The following is a description of a gene set: Mouse Gene Set: MIR_329_3P studied in species Mus musculus Genes predicted to be targets of miRBase v22 microRNA mmu_miR_329_3p in miRDB v6.0 with MirTarget v4 prediction scores > 80 (high confidence targets). from publication Chen Y, Wang X (PMID 31504780), and this is the list of marker genes: Grb2, Atp2a3, Rp2, Plaur, Luc7l2, Atxn1, Pcdha11, 4930596D02Rik, Fam53c, Piwil1, Pcdhac1, Ahnak, Ebf2, Zdhhc21 (NCBI Gene Id 68268), Bpifc, Ptchd4, Dclk1, Mark1 (NCBI Gene Id 98697), Bcl7a, Myo1b, Snrk, Kcnj5, Rnf19b, Dusp10, Nemp1, Ccer1, Ubn1, Zfyve1, Gigyf1, Ddx47, Pcdha6, Chmp3, Akap8, Npy5r, Pcdha4 (NCBI Gene Id 98129), Usp25, Tceal8, Atp11c, Lnpk, Dync2i2, Hey1, Trak1, Shb (NCBI Gene Id 230126), Ptprj, Bmerb1, Tnrc6b, Adam9, Csnk1g3, Mcf2l, Srsf4, Rmnd5a, Pcdha5, Map3k8 (mitogen-activated protein kinase kinase kinase 8), Ptx3, Slc17a6, Rabgap1, 1700028K03Rik, Zfp239, Mllt6, Arhgap11a (NCBI Gene Id 228482), Slc8a1, Pfkfb2, Larp4b, Pcdhac2, Rai1, Mapre1, Clec2h, Foxo1, Ppp1r14c, Tent4b, Pcdha7, Prkacb, Lhfpl4, Pcdha9 (protocadherin alpha 9), Pcdha10, Irf2bp2, Pcdha1, Ewsr1, Slc12a2, Fam184a, Commd6 (COMM domain containing 6), Nup93, Tbc1d24, Cep350, Btf3l4, Ddx19b, Zbtb18, Lrp2bp, Ssbp2, Bcl9 (B cell CLL/lymphoma 9, NCBI Gene Id 77578), Kbtbd2, Zfhx4, Maob, Fhip2a, D430041D05Rik, Epha4, Pes1, A330070K13Rik, Akain1, Slf2, Arhgap12, Coa7, Caprin1 (NCBI Gene Id 99144), Zfp26, Mgam (maltase-glucoamylase), Brd8, Ilrun, Raph1, Ppp1r3b, Eno2, Gpr146, Hpcal4, Slc16a10, Lonrf1, Pcdha2, Klhl2, Zfp281, Scml4, Dusp22, Rtl5, Phaf1, Pcdha12, Dlgap4, Or51e2, Blcap, Fezf1, Krit1, Pcdh10, Pcdha3